Given this list of marker genes MAGEL2, DUOX2, SNRPN, NDN, OCA2, here is a description of the gene set: Postterm pregnancy studied in species Homo sapiens A pregnancy that extends to 42 weeks of gestation or beyond. Human Gene Set: HP_POSTTERM_PREGNANCY